The following is a description of a gene set: Genes down-regulated in comparison of naive CD8 T cells versus memory CD8 T cells. CD8 T cells normally differentiate from resting naïve T cells into function effector and then memory CD8 T cells following acute infections. During chronic viral infections, however, virus-specific CD8 T cells often become exhausted. We used microarrays to examine the gene expression differences between naive, effector, memory and exhausted virus-specific CD8 T cells following lymphocytic choriomeningitis virus infection. species: Homo sapiens from publication Wherry EJ, Ha SJ, Kaech SM, Haining WN, Sarkar S, Kalia V, Subramaniam S, Blattman JN, Barber DL, Ahmed R (PMID 17950003) Human Gene Set: GSE9650_NAIVE_VS_MEMORY_CD8_TCELL_DN, and this is the list of marker genes: RNF19B, PCNA, PHYH, TENT5C, BCL2, PAM, SLCO3A1, CLDND1, ANXA1, TNFSF10, RPGR, ATF6, SH2D2A, ZMAT3, PPP3CC, POLR2L, FCGR2B, CDK4, HCFC1R1, CCR2, WEE1, MBD2, VKORC1, TMEM37, LGALS1, PHF13, CCL4, ITGAX, GPC1, IL18RAP, RPS6KA4, DENND5A, IL18R1, ELL2, AQP9, SNX10, CCND3, YES1, MOGS, PGAM1, MAP7D1, KITLG, N4BP1, POU6F1, ST3GAL6, TXN, CST7, PLSCR1 (NCBI Gene Id 5359), CASP4, TNFAIP3, RORA, SLC25A53, JUND, MID2, SLC35E4, NRP1, GATA3, CD160, EOMES, S100A11, CRIP2, TTC7B, LYSMD2, TNNI1, GZMK, LPIN1, KRTCAP2, ENPP1, FOSB, FOS, KLF4, CYB5R3, IQGAP2, SHC1, CRYBG1, RBMX, F2R, PRSS12, MYO1F, CASP1, TXNDC5, ST8SIA2, TRAPPC1, PRR13, EPN1, DPM3, HMGB2, DOCK5, UNC119B, FRAT1, FRMD5, PGLYRP1, ST3GAL4, YBX3, KCNJ8, TBL2, CXCR3, CNR1, FGR, KLRG1, S100A10, S100A4, IGF2R, RECK, CAPNS1, ITGB1, GDNF, CCR5, ANXA2 (NCBI Gene Id 792), ETFB, MDFIC, STMN1, SNTB2, DAPK2, EEA1, GLRX, GABARAPL2, SORL1, PTPN13, CYFIP2, SLX9, ERRFI1, TNFRSF1B, S100A13, NFKBIB, IL10RA, ZFP36L2 (NCBI Gene Id 96706, ZFP36 ring finger protein like 2), HLA-A, HOPX, IFNG, HS1BP3, ADAM19, BHLHE40, KLRK1, GSTO1, MX2 (MX dynamin like GTPase 2), ITGA4, MAPRE2, ID2, PACS1, DPP7, S100A6, CTSD, GBP4, AOPEP, NUCB1, KLF10, CHPT1, CTSW (NCBI Gene Id 8849), NBEAL2, KLF6, ITGB7, MNS1, TSPAN31, PTTG1, NELFE, CTLA4, SEPTIN1, SH2D1A, GNPTG, CDC34, XRCC5 (X-ray repair cross complementing 5), PIM1, AARS1, ACOT7, CCL5, LYPLA2, TOB1, FASLG, CAPN2 (NCBI Gene Id 824), PRDX2, TULP4, FGF19, FGL2, CRTAM, LRRC8C, H1-0, ODC1, EMP1, IFITM10, PFKP, UBC, PRF1, DYM, GZMB, HASPIN, UNC119, GADD45B, EFHD2, KLRC1, FGF13, XDH, RNF138, CD7, COX17, GZMM, AHNAK, ATN1, CD44, BCL2A1